Given this list of marker genes UBE2I, RANGAP1, SUMO1, here is a description of the gene set: SUMOylation of RANGAP1 and LMNA affect their localization at the nuclear envelope. SUMOylation of NUP153 has unknown consequences. Reactome Pathway: SUMOylation of nuclear envelope proteins part of: SUMO E3 ligases SUMOylate target proteins studied in species Homo sapiens